The following is a description of a gene set: The regulated release of epinephrine by a cell. Epinephrine is a catecholamine hormone secreted by the adrenal medulla and a neurotransmitter, released by certain neurons and active in the central nervous system. Human Gene Set: GOBP_EPINEPHRINE_SECRETION species: Homo sapiens, and this is the list of marker genes: CARTPT, CRH, ADRA2C, ADRA2A, GABBR1, ADRA2B, VIP